Given this list of marker genes SMARCB1, CTNNB1, TERT, SUFU, GHSR, PIK3CA, NFKB2, GNB2, AKT1, HS6ST1, BRAF, KIAA0753, SMARCE1, MED12, TRAF7, SMO, MAGEL2, NF2, FANCI, COG2, SIM1, RNU4-2, BAP1, NDE1, VSX1, ZFX, FGF8, RBM28, MAST3, CDH23, PDGFB, here is a description of the gene set: Abnormal size of pituitary gland A deviation from the normal size of the pituitary gland. Human Gene Set: HP_ABNORMAL_SIZE_OF_PITUITARY_GLAND species: Homo sapiens